The following is a description of a gene set: studied in species Homo sapiens Human Gene Set: GOBP_NEGATIVE_REGULATION_OF_POTASSIUM_ION_TRANSMEMBRANE_TRANSPORT Any process that stops, prevents or reduces the frequency, rate or extent of potassium ion transmembrane transport., and this is the list of marker genes: CAV1 (NCBI Gene Id 857), MIR26A1, NEDD4, GRP, KCNE2, KCNH2, RGS4, KEL, BIN1, MIR29B1, KCNQ1, WWP2, CAV3, MIR212, KCNRG, STK39, MIR30D, SUMO1, ANK3, MIR103A1, CAB39, KCNE1, KCNAB1, NEDD4L, KCNE5, KCNE3, OXSR1